Given this list of marker genes Il12rb1, Stard10, Cep55, Fignl1, Nrn1, Rad54l, Pbk, Odc1, Cenpf, Unc119, Cst7, Slc25a53, Gzmb, Acot7, Mms22l, Bmp7, Tmem38b, Ksr1, Ifi44, Alad, Rpl17, Fbxw8, Dctd, Nedd4, 6330403K07Rik, Nusap1, Irf8 (interferon regulatory factor 8), Pclaf, Myo1f, Aurka (aurora kinase A), Hmmr, Ccnb1, Spc25, Kif2c, Ccnb2, Mtmr7, Cysltr2, Cks1b, Cenpk, Rrm2, Nuf2, Slc39a4, Cmpk2, Cenpe, Pdcd1lg2, Vars2, Rasgrp2, Snx9, Birc5, Chdh (NCBI Gene Id 63829), Igf2bp3, Abcb1a, Cdca5, H1f2, Ar, Gins2, Zcchc18, Cdc20, H3c15, Tgfbr2, Kif20a, Clspn, Nek2, Cdca3, Ebi3, Gemin8, Atf6, Aspm, Aurkb (NCBI Gene Id 20877), D17H6S56E-5, Tpx2, Ncapg2, Ccna2, Lgals3, Cdca8, Ccr2, Spag5, Tnfrsf9, Spc24, Bub1, Tk1, Serpina3g, Abhd4, Icam1, Mcm10, Cdk1, Rad51, Bub1b, Il17rb, Plk1, Tyms, Tktl1, St8sia6, Tpi1, Ncapg, here is a description of the gene set: studied in species Mus musculus Cluster P6 of genes with similar expression profiles in peripheral T lymphocytes after FOXP3 loss of function (LOF). Regulatory CD4+ T cells (Tr cells), the development of which is critically dependent on X-linked transcription factor Foxp3 (forkhead box P3), prevent self-destructive immune responses. Despite its important role, molecular and functional features conferred by Foxp3 to Tr precursor cells remain unknown. It has been suggested that Foxp3 expression is required for both survival of Tr precursors as well as their inability to produce interleukin (IL)-2 and independently proliferate after T-cell-receptor engagement, raising the possibility that such 'anergy' and Tr suppressive capacity are intimately linked. Here we show, by dissociating Foxp3-dependent features from those induced by the signals preceding and promoting its expression in mice, that the latter signals include several functional and transcriptional hallmarks of Tr cells. Although its function is required for Tr cell suppressor activity, Foxp3 to a large extent amplifies and fixes pre-established molecular features of Tr cells, including anergy and dependence on paracrine IL-2. Furthermore, Foxp3 solidifies Tr cell lineage stability through modification of cell surface and signalling molecules, resulting in adaptation to the signals required to induce and maintain Tr cells. This adaptation includes Foxp3-dependent repression of cyclic nucleotide phosphodiesterase 3B, affecting genes responsible for Tr cell homeostasis. Mouse Gene Set: GAVIN_FOXP3_TARGETS_CLUSTER_P6 from publication Gavin MA, Rasmussen JP, Fontenot JD, Vasta V, Manganiello VC, Beavo JA, Rudensky AY (PMID 17220874)